The following is a description of a gene set: Mouse Gene Set: GOBP_CMP_METABOLIC_PROCESS studied in species Mus musculus The chemical reactions and pathways involving CMP, cytidine monophosphate., and this is the list of marker genes: Upp2, Upb1, Cda, Uck2, Dpys, Uck1, Uckl1, Upp1, Dck, Nt5c3, Dpyd